Given this list of marker genes Gdnf, Wnt9b, Cited1, Sall1, Stat1, Ctnnb1, Lif, Pax8, Pax2, here is a description of the gene set: Mouse Gene Set: GOBP_REGULATION_OF_MESENCHYMAL_TO_EPITHELIAL_TRANSITION_INVOLVED_IN_METANEPHROS_MORPHOGENESIS Any process that modulates the rate, frequency or extent of the transition where a mesenchymal cell establishes apical/basolateral polarity,forms intercellular adhesive junctions, synthesizes basement membrane components and becomes an epithelial cell that will contribute to the shaping of the metanephros. studied in species Mus musculus